Given this list of marker genes ZKSCAN1, SETD2, TSPAN6, RCL1, EIF2B4, TMEM106C, ZNF512B, SSNA1, LSP1, GPR155, ZDHHC18 (NCBI Gene Id 84243), HABP4, RAF1, CRTC3, WWOX, ISCU, INTS1, HLA-DRB1, VPS9D1, NCOA1, TWF1, DDI2, CHST14, H2BC13, GLOD4, UBR5, SPHK2, DPM2, KCTD6, RNF11, SPTLC1, CCR4, PDHA1 (NCBI Gene Id 5160), RRAS, DNAJC8, LDAH, PCNP, PLIN3, PKP2, C19orf12, HSDL2, METAP1D (methionyl aminopeptidase type 1D, mitochondrial), GSS, PPP2R3C, ARSG, SOX4, RGS11, ACOT9, SEC11A, HLA-DQA1, RGCC, CYP11A1, RPAIN, PPM1F (protein phosphatase, Mg2+/Mn2+ dependent 1F), STXBP1, KRBA1, MSR1, WBP4, TNKS, PRKDC, RAI1, GNGT2, BEX2, DYNLT3, CRLF3, MEAK7, RAB3GAP2, PLA2G7, CTDNEP1, ARID1A, ATP6V0D1, AGL, METTL5, PHF23, ARHGAP5 (NCBI Gene Id 394), USP22, CD5, KCND1, PHKA1, ZMIZ2, GMIP, SPOP, SLC7A6, SCD (stearoyl-CoA desaturase), DDX5, ZFC3H1, RER1, MLEC, CSTPP1, STAB1, CCDC43, EIF3F, IK, EIF4B, ADCY6, RELCH, MANSC1, CBX6, CYP2R1, PITHD1, CACNB3, TPP1, LENG1, GPR174, SLC15A2, ZNF560, TRPC4AP, LPL, UTP14A, AKAP13, IPO8, FBXO11, ERAL1, WDFY2, OTULINL, INHBA, SERINC5, PABPC5, SUN2, ANAPC7, STYX, MALAT1, ADAM12, YTHDC1, RPL35, SH3YL1, BLVRB, KMT2D, FAM234A, ZNF623, PAQR8, PNISR, SLC39A1, MIA3, RANBP9, ACVRL1, RPS8, B3GNT8, SMIM3, SETD6, ZNF629, CCNDBP1, DDX6, CD44, HSPBAP1, PSMD4, CDC37L1, ZFP36L2, MCAM, TFCP2, TPD52, HECTD4, ENG, HK2, CFB, DALRD3, INPP5B, ZNF32, RB1, CCDC47, S1PR3 (NCBI Gene Id 414320), DHX30, SELENOM, HDAC1, KIDINS220, LRCH1, SLC2A6, PLGRKT, GCN1, CEP83-DT, EPC1, USP33, NUAK1, PRLR, RBM5, WDR48, JUNB, CFAP418, SASH3 (NCBI Gene Id 93952), CNN2, SNN, COL6A3, NUMA1, HDAC10, DHRS4, RBL2, CLK4, S100A3, RPL31, TSPAN5, PKD1, INPPL1, IDH2, TINAG, IFT74, ARFIP1, SMG1, PLCXD1, AAMP, CNTRL, here is a description of the gene set: studied in species Homo sapiens Human Gene Set: GSE14308_TH1_VS_TH17_DN Multipotential naïve CD4+ T cells differentiate into distinct lineages including T helper 1 (Th1), Th2, Th17, and inducible T regulatory (iTreg) cells. The remarkable diversity of CD4+ T cells begs the question whether the observed changes reflect terminal differentiation with heritable epigenetic modifications or plasticity in T cell responses. We generated genome-wide histone H3 lysine 4 (H3K4) and lysine 27 (H3K27) trimethylation maps in naïve, Th1, Th2, Th17, iTreg, and natural (n)Treg cells. We found that although modifications of signature cytokine genes (Ifng, Il4, and Il17) partially conform to the expectation of lineage commitment, critical transcription factors such as Tbx21 exhibit a broad spectrum of epigenetic states, consistent with our demonstration of T-bet and IFN-gamma induction in nTreg cells. Our data suggest an epigenetic mechanism underlying the specificity and plasticity of effector and regulatory T cells and also provide a framework for understanding complexity of CD4+ T helper cell differentiation. from publication Wei G, Wei L, Zhu J, Zang C, Hu-Li J, Yao Z, Cui K, Kanno Y, Roh TY, Watford WT, Schones DE, Peng W, Sun HW, Paul WE, O'Shea JJ, Zhao K (PMID 19144320) Genes down-regulated in comparison of Th1 cells versus Th17 cells.